Given this list of marker genes IER3, TUBA3C, HSP90AB1, TUBA4A, CXCL1, GNAS, MRPS22, SNRPF, SLC16A9, HNRNPUL1, PTTG1, METAP2 (methionyl aminopeptidase 2), UBA1, CKAP4, TFAP2A, TMSB4X, ECH1, DAD1, ALG3, HNRNPA3P1, DNER (delta/notch like EGF repeat containing), TUBA3D, TUBB, CPLX2, GNAI2, PSMD2, here is a description of the gene set: Human Gene Set: TOMIDA_METASTASIS_UP species: Homo sapiens Up-regulated genes associated with the acquision of metastatic potential in LNM35 cells (large cell lung cancer). Although widespread metastasis is the major cause of human lung cancer-related deaths, its underlying mechanism remains largely unclear. Our genome-wide comparison of the expression profiles of a highly metastatic lung cancer cell line, NCI-H460-LNM35 (LNM35), and its parental clone, NCI-H460-N15 (N15), resulted in the identification of a cancer metastasis signature composed of genes. Through gene ontology analysis, our study also provided insights into how this 45-gene metastasis signature may contribute to the acquisition of metastatic potential. By applying the signature to datasets of human cancer cases, we could demonstrate significant associations with a subset of cases with poor prognosis not only for the two datasets of cancers of the lung but also for cancers of the breast. Furthermore, we were able to show that enforced expression of the DLX4 homeobox gene, which was identified as a gene with significant downregulation in LNM35 as well as with significant association with favorable prognosis for lung cancer patients, markedly inhibited in vitro motility and invasion as well as in vivo metastasis via both hematogenous and lymphogenous routes. Taken together, these findings indicate that our combined transcriptome analysis is an efficient approach in the search for genes possessing both clinical usefulness in terms of prognostic prediction in human cancer cases and clear functional relevance for studying cancer biology in relation to metastasis. from publication Tomida S, Yanagisawa K, Koshikawa K, Yatabe Y, Mitsudomi T, Osada H, Takahashi T (PMID 17260014)